The following is a description of a gene set: species: Mus musculus from publication Chen Y, Wang X (PMID 31504780) Mouse Gene Set: MIR_669A_5P_MIR_669L_5P_MIR_669P_5P Genes predicted to be targets of miRBase v22 microRNA mmu_miR_669a_5p, mmu_miR_669l_5p, mmu_miR_669p_5p in miRDB v6.0 with MirTarget v4 prediction scores > 80 (high confidence targets)., and this is the list of marker genes: 2510009E07Rik, Ikzf4, Lrrtm1, 4931406C07Rik, Brwd3, Myrip, Stt3b, Pde3a, Gm5141, Nppc, Zfp1008, G3bp2, Capn3, Has2, Bcl2, Pum2, Aff4 (AF4/FMR2 family, member 4), Gm3604, Cp, Bcor, Dmd, Rabgap1l, Lhx2, Aldh1l2 (aldehyde dehydrogenase 1 family, member L2), Kpna1, Atad2, Zfp59, 5730455P16Rik, Gabrr1, Cdk17, Map7d1, Tbc1d13, Cd86, Sh3kbp1, H2-D1, Ttc28 (tetratricopeptide repeat domain 28), Dpysl2, Mxra8, Tor1aip1, Ppp2r2d, Trpc6, Lcp2, Rad52, Pcdh10, Lrrc74b, Porcn, Maml2, Nrxn1, Insyn2b, Atxn1, Nxph1